Given this list of marker genes EVC, MEG3, DLK1, RUNX2, COL2A1, SOX9, CREBBP, RIPK4, COL9A1, IHH, ARSB, EED, ERCC8, TBX15, ERCC6, FN1, EVC2, CCBE1, LYSET, TRAPPC2, DYM, NKX3-2, RTL1, WNT7A, HDAC6, CTSK, EP300, SMAD4, EZH2, LAMA5, PCNT, here is a description of the gene set: Hypoplastic iliac wing Human Gene Set: HP_HYPOPLASTIC_ILIAC_WING Underdevelopment of the ilium ala. species: Homo sapiens